The following is a description of a gene set: studied in species Homo sapiens Abnormality of the knee An abnormality of the knee joint or surrounding structures. Human Gene Set: HP_ABNORMALITY_OF_THE_KNEE, and this is the list of marker genes: SELENON, MEGF10, SYT2, FHL1, BAZ1B, LGI4, MMP9, PUS3, MAP1B, MAP3K7, PIEZO2, KIF22, CYP2R1, TOR1A, PWRN1, CHST11, SCYL2, LAMB2, LBR, DONSON, IFT56, FKBP10, SCN1A, NF1, B3GAT3, FBN2 (fibrillin 2), IDUA, RPL10, HSPG2, MATN3, PRKACA, SLC25A46, COL2A1, CANT1, IDH1, PWAR1, COL5A1, FGF13, PHLDB1, EBP, UFD1, MAPK8IP3, GLB1, LIFR, PDGFRB, HS6ST1, TPM2, PCDH19, MYL2, CENPT, HBB, ALG2, NT5C2, SVIL, POLRMT, SLC26A2, PIGY, BRAF (B-Raf proto-oncogene, serine/threonine kinase), ITGA7, TBL2, HCN1, COL7A1, SCN1B, UBR7, SNORD115-1, STAT4, PRG4, GLI1 (GLI family zinc finger 1), SEC24C, CHST3, GABRD, SHH, CTCF, RUNX2, FBN1, PIK3R2, CHRNB1, WNK1, CLCN7, C19orf12, MKRN3, HYAL1, CYP19A1, KIF1A, MEFV, HACD1, NRAS (NCBI Gene Id 4893), ECEL1, TRIP11, GNB2, TPM3, NALCN, NCF1, CYP27B1, STX5, CDC6 (cell division cycle 6), IFT57, CTC1, RREB1, HRAS, FZD2, FN1, ACTA1, SYNE1, CTNS, COL6A3, ABCC6, TCTN3, IARS2, ARF1, EZH2, RPGRIP1L, TELO2, UFSP2, GRIA3, CLDN16, HIRA, MAB21L2, SHOX (NCBI Gene Id 6473), PTPN22, HS2ST1, LMBR1, SLC18A3, NAA60, JMJD1C, RECQL4, GFPT1, ATP6V1E1, KY, CHRNG, BCOR, IFIH1, JAG2, TRAPPC2, PSTPIP1, MYL11 (myosin light chain 11), COG8, IDH2, SCN9A, LTBP1, UGP2, DNMT3A, COMP (NCBI Gene Id 5659), PRKACB, IHH, P4HTM, CBS, TONSL, WASF1, CFL2, AHDC1, DNAJC30, RMRP, EVC, ORC1, ERI1, ORC6, AP4E1, PRMT7, METTL27, PRRT2, SNAP25, FILIP1 (NCBI Gene Id 27145), EFL1 (elongation factor like GTPase 1), RFC2, TRIM2, EVC2 (EvC ciliary complex subunit 2), TBC1D7, DDR2, DPYSL5, AP4M1, ANO5 (anoctamin 5), GPC6 (NCBI Gene Id 10082), COL9A2, MYO9A, PDE4D, NEDD4L, ARVCF, COL25A1, PTH1R, EIF4H, VCP, HEATR3 (HEAT repeat containing 3), MYH3, RAD21, DYM, BMP1, TGFB1, MEGF8, PITX1, PRKAR1A, COX11, MPZ, H3-3B, AP4S1, GLI3, CRELD1, DYNC2LI1, SPTBN1, AIFM1, EIF2AK3, ACAN, DHX16, EXT1, SCN4A, UNC80, GTF2IRD1, PLOD1, NSD1, ERGIC1, TRPS1, ENPP1, COL6A1, ASAH1, TNFSF11, DMP1, KAT6B, ANAPC1 (anaphase promoting complex subunit 1), ARSB, BUD23, HERC2, COL10A1, MIA3, TTI1, COL1A2, RAB23, PI4KA, TGDS, GTF2I, ARL6IP1, COL6A2, MYOT, GABRG2, ERCC1, ZSWIM6, ELN, DPM1, WNK3, MMP13, ARSK, NKX3-2, SLC35A3, TRPV4, ARFGEF2, IFT172, SATB2, ADNP, COL11A1, HPGD, MAGEL2, SDHB, CBFB, RETREG1, WNT7A, TBX4, SFRP4, FLNA, ALG14, HNRNPH1, HGD, ATRX, B4GALT7, ANKRD55, PRR12, FGFR3, GTF2IRD2, DDRGK1 (DDRGK domain containing 1), STX1A, WDR62, LMBRD2, ZEB2, SRD5A3, YY1, MAP2K2, FGD1, NFATC2, SLCO2A1, VDR, ARID1B, ORC4 (origin recognition complex subunit 4), IL2RB, BAG3, SMAD2, BICD2, COL5A2, IL2RA, NPAP1, RPL13, CD247, PEPD (NCBI Gene Id 84738), CSGALNACT1, GNPTG, GALNS, SH3PXD2B, SNORD116-1, MAP3K20, NOTCH2, LMNA, EMD, GUSB, CLIP2, VPS13B, LIMK1, BGN, IPO8 (NCBI Gene Id 10526), POLR3A, STX1B, PLOD2, SDHD, KAT6A, CDC45, ADGRV1, SLC6A9, COL1A1, COLQ, SCN2A, STXBP1 (syntaxin binding protein 1), KLHL41, PLAAT3, SF3B2, RYR1, MAN2B1, GJB6, LONP1, VPS37D, TAF4, SCARF2, UBA1, TFE3, FDFT1 (NCBI Gene Id 2222), FBLN5, TMEM270, SOX9, SLC39A8, MAP2K1, LMOD3, PTPN2, DPAGT1, ATP7A, SERPINH1, KRAS (NCBI Gene Id 3845), EXOC6B, FLNB, DYSF, B3GALT6, ZNF699, EP300, CYP3A4, SKI, ZPR1, GJB2, RAB33B, PTEN (phosphatase and tensin homolog), USP9X, NEPRO, COL9A1, CAMK2A, AEBP1, NDUFAF6, XYLT1, COL9A3, KRT5, BMP4, SIK3, MTX2, UFC1, CREBBP, ANKLE2, TBX1, GNPTAB, TMTC3, SMAD3 (SMAD family member 3), CCN6, PMP22, CPT2, RNU4ATAC, GP1BB, ERLIN1, BPNT2, CDT1, FKBP6, BRF1, COG5, MAN2C1, ERCC6, OCRL, GMNN, BHLHA9, FLNC, ZBTB20, DMD, PIK3CA, GDF5, RSPRY1, GABRA1, ASCC3, ALDH18A1, KIF7, SDHA, CTDP1, GMPPB (GDP-mannose pyrophosphorylase B), RTTN, MYL1, GNPAT, PRKG2, TUBB3, COMT, MCTP2, EXT2, CNTNAP1, SDHAF1, GAN, ADAMTS15, ERMARD, PTDSS1, RBM8A, SPART, SLC10A7, PIGA, COL12A1, NLRP3, ERLIN2, TNFRSF1A, PKDCC, AP4B1, PHEX, ESCO2, MCOLN1, LMX1B, SLC35B2, NEB, PSAT1